The following is a description of a gene set: TNF-JNK signaling pathway. Pathway ID: N00446. Pathway type: Reference. Pathway class: nt06516 TNF signaling. species: Homo sapiens Pathway Definition from KEGG: TNF -> TNFRSF1A -> (RIPK1+TRADD+TRAF2/5) -> (TAK1+TAB1/2) -> MKK4/7 -> JNK -> AP1 Human Gene Set: KEGG_MEDICUS_REFERENCE_TNF_JNK_SIGNALING_PATHWAY, and this is the list of marker genes: MAP2K4, TRAF5, MAPK8, RIPK1, TNF, JUN, TNFRSF1A, TAB2, MAPK9, TAB1, FOS, TRAF2, MAPK10, MAP3K7, MAP2K7, TRADD